Given this list of marker genes POP1, POP7, POP5, RPP21, RPP40, POP4 (POP4 homolog, ribonuclease P/MRP subunit), RPP38, RPP14, RPP30, RPP25, here is a description of the gene set: Binding to RNA subunit of ribonuclease P. species: Homo sapiens Human Gene Set: GOMF_RIBONUCLEASE_P_RNA_BINDING